The following is a description of a gene set: from publication Chen Y, Wang X (PMID 31504780) Genes predicted to be targets of miRBase v22 microRNA hsa-miR-5683 in miRDB v6.0 with MirTarget v4 prediction scores > 80 (high confidence targets). studied in species Homo sapiens Human Gene Set: MIR5683, and this is the list of marker genes: MEF2C, ATP6V1E1, ADAMTS9, TMEM182, TYSND1, STK26, PCDHA1, TAL1, USP27X, RO60, MED20, NCOR1, EPC1, KIAA1586, MFAP3L, NIPSNAP3B, PCDHA2, HIVEP3, CCDC141, ZNF124, RABGGTB, SLC30A6, SCLT1, TOMM70, TBX18, MINK1, ACLY, MTMR1, TCEA1, YWHAE, ENTPD7, RPL15, COL6A5, TMEM33 (NCBI Gene Id 55161), MEMO1, TSPYL1, CACNB4, AFAP1L2, DBH, NEMF, AXIN2, HAO1, PRPF40A, MBTD1, TMIGD1, TNFRSF11B, CNOT6, PRKAA1, ZNF133, IQCH, ARHGAP36, LMBRD1, BFAR, RYBP, ULK2, PCDHA7, ETS2, PRKG1, TAOK1, SLC25A43, ZFAND5, ZNF431, BCKDHB, PCDHA6, DNAJB4, PCDHA13, SLC30A7, FNDC3B, ZBTB38, GABRB2, MUCL3, ZNF277, PCDHA11, QNG1, NEU3, PCDHA3, ANP32A, SPATA6, CPEB3, ST8SIA2, SLC25A44, DIP2B, CD59, NECAB1, TRA2B, NCKAP1, RSBN1, KIF5C, NAV1, SYNPO2, PPM1N, AFDN, MOSMO, FMR1, TUBB1 (tubulin beta 1 class VI), MMS22L, RFC3, SLC35G3, RTF1, MYEF2, HLA-DRB5, CADM2, CXXC4, RAB9B, NECAP1, CYP3A7-CYP3A51P, STYK1 (serine/threonine/tyrosine kinase 1), DCBLD2, SERTAD4, IQSEC3, MGA, KAT7, ARSJ, RBMS3, ZKSCAN8, ARHGAP15, MS4A3, PPM1B, TPM3, SLC15A5, SETD7, ATN1, ENDOV, HDLBP, CXXC1, MACROH2A2, ELAVL2, ZNF608, SCPEP1, BPTF, HOXD10, PCDHAC1, SHROOM3, FBXL19, CPLX3, ASXL1, SYNPR, CNBP, TMOD2, IRF9, CYB5B, MGST1, PARP15, ISX, LRIG1, PCDHA8, SNRK, YPEL5, AFF1, CAMKK1, LYPLAL1, KDELR2, AMPH, MREG, ZNF670, ITGA4, ATP2A2, GFOD1, ENSG00000255537, PDCD10, TMA7, RHOBTB3, PJA2, KAT6B, BICD2, RAP1A, DCLK1, PCDHA5, KCTD21, ATXN7, DTX3L (NCBI Gene Id 151636), CCDC81, KHSRP, HSD17B4, CEP70, PCM1, EEA1, DIS3, ASAP2, LACTB, SENP1, PCDHA4, XKR4, GAS6, SHOC2, RALGPS2, DENND1B, TMEM214, ONECUT2, UGCG, SH3RF1, DUOXA1, NDFIP2, C1QL3, CANX, CSPP1, TMEM130, FAHD1, AK4, HNRNPU, DEPDC1, PTBP3, KCNN3, VLDLR, RIC8B, PCDHA12, NR3C1, TMEM255A, MAPK9, COLGALT2, KCNMA1, MOB2, PALS2, CNTNAP3B, CYB5R2, ZNF189, RANBP2, PCDHAC2, BAHD1, PCDHA10, DMRT2 (doublesex and mab-3 related transcription factor 2), DACT3, MEGF11, STAU2, RBBP6 (NCBI Gene Id 84712), TSPAN2, PSMD11, MAP3K2, HS6ST2, ADSS2, CDC42EP3, FYTTD1, SLC4A9, PPP1R15B, AGA, OTX2 (orthodenticle homeobox 2), CTTNBP2NL, INO80D, PABPC1L2B, GRM3, TSTD3